Given this list of marker genes ZNRF2, FAIM2, OSBPL7, GIGYF2, SLF2, CLIC1, TMEM63B, FGFRL1, TCF19, CREBZF (NCBI Gene Id 58487), CYTH3 (NCBI Gene Id 9265), here is a description of the gene set: studied in species Homo sapiens Human Gene Set: MIR4669 Genes predicted to be targets of miRBase v22 microRNA hsa-miR-4669 in miRDB v6.0 with MirTarget v4 prediction scores > 80 (high confidence targets). from publication Chen Y, Wang X (PMID 31504780)